Given this list of marker genes Camk2a, Il9, Tyk2, Leprot, Cenpj, Ifnb1, Wdr48, Gadd45a, Ptprc, Fam3c, Prl7a1, Irf1, Prl6a1, Gh, Rac1, Pparg, Ep300, Prl4a1, Prl7a2, Sac3d1, Pigu, Crlf2, Hmga2 (high mobility group AT-hook 2), Mgat5, Ifng, Kit, Prl8a1, Prl3a1, Prl2b1, Lif, Dab1, Ret, Calm2, Prl2c3, Ggnbp2, Prl7c1, Nlk, Egf, Adipor1, Il7r, Prl2a1, Socs1, F2r, Il10rb, Crlf3, Prl3d3, Ptprt, Prl3d1, Prl7b1, Cav1, Cdk5r1, Prl2c5, Hnf4a, Ercc6, Suz12, Hes1, Clec12b, Il10, Inpp5f, Prl8a2, Il10ra, Ptprd, Usp1, Bcl3, Il6, Socs3, Akr1b1, Jak2, Elp2, Prl, Dot1l, Mir301, Cdk5, Erbb4, Nf2, Socs2, Ghr (growth hormone receptor), Calm3, Calm1, Cyp1b1, Prl2c2, Prl8a6, Ephb2, Gbp7, Tnf, Prl3d2, Parp14, Neurod1, Agap2, Tslp, Lep, Prl8a8, Stra6, Prl7d1, Il20 (NCBI Gene Id 58181), Cish, Pibf1, Mst1, Ptk2b, Prl3c1, Tbx1, Il4 (NCBI Gene Id 16189), Sh2b3, Jak1, Ccl5, Hes5, Traf3ip1, Prl2c1, Prl3b1, Ptpn2, Prlr, Hgs, Notch1, Tgfb1, Prl5a1, Il5, Cntf, Cxcl5, Prl8a9, Il3, here is a description of the gene set: Any process that modulates the frequency, rate or extent of receptor signaling via STAT. studied in species Mus musculus Mouse Gene Set: GOBP_REGULATION_OF_RECEPTOR_SIGNALING_PATHWAY_VIA_STAT